The following is a description of a gene set: from publication Chen Y, Wang X (PMID 31504780) species: Homo sapiens Human Gene Set: MIR655_5P Genes predicted to be targets of miRBase v22 microRNA hsa-miR-655-5p in miRDB v6.0 with MirTarget v4 prediction scores > 80 (high confidence targets)., and this is the list of marker genes: ENDOU, EEF1E1, ACBD5, ARMH3, LRCH1, FYCO1, NR4A3, TUSC3, CHTF8, E2F7, ZC3H4, CXCL12, NR6A1, HTR4, KLF12, EVA1A, HCN1, LUZP2, FOXL1, RNF19A, PCDH15, IPO5, HGF, PUS1, RHOB (ras homolog family member B), LRRC34, SYT11, PROSER2, WDCP (WD repeat and coiled coil containing), FKBP1A, MED13, FBN2, PRKCA, HLA-DQA1, ASCC3, ADGRB3, KCTD16 (NCBI Gene Id 57528), KIF3C, SYT4, ERLIN2, MSL2 (NCBI Gene Id 55167), RNF126, C5orf47, MASTL, LRRTM3, RAI14, TSN, RPAP2, ST18, TBX18, SNX4, PXDN, MCCD1, KDM7A, HIF3A, NRBF2, ARRDC4 (NCBI Gene Id 91947), KAT6A, ARL8A (NCBI Gene Id 127829), CEP76, PIAS3, RAB7A, PLAGL2, PHF20, GNB1, ANGPTL3, ZFP3, LYRM1 (LYR motif containing 1), OLFML1, SLCO5A1, AGO1, DIPK1A, CCER1, GPR12, ZBTB34, TRIO, DSTN, TRIM24 (tripartite motif containing 24), SMARCC1